Given this list of marker genes Rabl3, Ugt1a9, Smarcc1, Pgk1, Ugt1a1, Zfp280c, Zc3h12c, Cadm1, Mta2, Ska2, Map2k4, Pcdha3, Camk2d, Uhrf2, Camsap2, Zfp655, Pcdha2, Sp9, Icos, Saraf, 5730480H06Rik (RIKEN cDNA 5730480H06 gene), Ubn1, Tor1aip2, Ywhag, Ubxn7, Arl5a, Rsrc2, Mier2, Tm6sf1, Npr3, Ell, Micu3, Ss18l1, Fyttd1, Nek7, Ugt1a2, Hltf, Arid5a, Ppm1k, Ctps1, Smad7, Fmo5, Ddx4, Ube4b, Spop, Clec9a, Alcam, Cdc42 (cell division cycle 42), B4galt6, Phyhipl, Pcdh19, Slc25a17, Togaram1, Utp6, Bex4 (brain expressed X-linked 4), Stmn4, Lox, Zfp871, Arhgap6, Prkd3, Ubr5, Mycl, Pcdha6, Lamp1, Spic, Zfhx3, Tiam1, Ugt1a7c, Gad2, Med13, Tmcc3, Zic5, Chordc1, Mlx, Ugt1a6a, Prkg1, Rnf183, Herc3, Pcdha7, Henmt1, Kirrel3, Cenpq, Pcdha5, Trio, Ppp1r3a, Smarce1, Pwwp3b, Ugt1a5, Kin, Shtn1, Pgr15l, Pdcd10, Gpr22, Srcin1, Ppp1r1a, Gria2, Myo9a, Pde4b, Fez2, Pcdha10, Nufip2, Srsf2, Abcb1b, Pcdhac2, Pcdha11, Lbr, Cpeb2, Pcdha9, Rtn3, Map3k1, Mest, Pcdha4, Ugt1a10 (UDP glycosyltransferase 1 family, polypeptide A10), Glt8d2, Atp2b1, Dnajb4, Rps6ka6, Pgap1, Slc35b3, Naca, Nap1l5, Pabir1, Pcdha1, Pcdhac1, Pcdha12, Srsf7, here is a description of the gene set: Genes predicted to be targets of miRBase v22 microRNA mmu_miR_122b_3p in miRDB v6.0 with MirTarget v4 prediction scores > 80 (high confidence targets). Mouse Gene Set: MIR_122B_3P from publication Chen Y, Wang X (PMID 31504780) species: Mus musculus